Given this list of marker genes TNFSF13B, HERC5, MAPK11, PSG6, HERC6, FXYD3, ZFAT, C15orf48, PSG11 (NCBI Gene Id 5680), CD24, SECTM1, ALDH1B1, CLDN16, RNASE1, APH1B, KLRC2 (killer cell lectin like receptor C2), KLRC3, ARHGEF37, HLA-F, SLC2A10, SHFL, FRMD5, MALAT1, MDK, THEMIS2, C1S, ZBTB20, CLEC2D, SNED1, ALPP, TGFB2, FOLR1, PLAAT2, IFI30, ID3, PSMB9, EPB41L4A, ST6GALNAC2, SOX4, TAPBPL, AKR1C3, OLFML2A, OFD1, PLAAT4, RTP4, LYPD5, KRT17, LRRC4C, SMIM14, TNNC1, BDH2, KCNMB1, BPHL, PSG1, AQP3, KRT14, HMOX1, SAA1, MUC20, PYCARD, GCM2, DNM1P41, DUSP4, CNTNAP1, BTN1A1, IL32, RCN3, TMCO4, SLC15A3, PARP9, IFITM1, SLC1A2, ENPP5, here is a description of the gene set: Genes up-regulated in PCI-35 cells (pancreatic cancer, lack endogenous DUSP6) upon expression of DUSP6 off an adenoviral vector. DUSP6/MKP-3, a specific inhibitor of MAPK1/ERK2, frequently loses its expression in primary pancreatic cancer tissues. This evidence suggests that constitutive activation of MAPK1 synergistically induced by frequent mutation of KRAS2 and the loss of function of DUSP6 plays key roles in pancreatic carcinogenesis and progression. By profiling of gene expressions associated with downregulation of MAPK1 induced by exogenous overexpression of DUSP6 in pancreatic cancer cells, we found that AURKA/STK15, the gene encoding Aurora-A kinase, which plays key roles in cellular mitosis, was among the downregulated genes along with its related genes, which included AURKB, TPX2 and CENPA. An association of expression and promoter activity of AURKA with MAPK activity was verified. Knockdown of ETS2 resulted in a reduction of AURKA expression. These results indicate that AURKA is a direct target of the MAPK pathway and that its overexpression in pancreatic cancer is induced by hyperactivation of the pathway, at least via ETS2. from publication Furukawa T, Kanai N, Shiwaku HO, Soga N, Uehara A, Horii A (PMID 16532023) studied in species Homo sapiens Human Gene Set: FURUKAWA_DUSP6_TARGETS_PCI35_UP